Given this list of marker genes PDX1, COPA, STAT2, NF2, TET2, CHEK2, KCNJ5, BMPR1A, MYD88, VHL, BICD2, GP1BA, F11, XYLT2, LRP5, ERAP1, LBR, CST3, NF1, MDH2, ARPC1B, SLC7A7, CFHR1, MEN1, COMT, APC (APC regulator of WNT signaling pathway), JAK2, INS, PDCD1, CBL, TAOK1, CALR, CLCN2, PKHD1, GALE, PCCB, PROC, KIF1B, CNTNAP2, WIPF1, VWF, LAMB2, SMAD4, NLRC4, TBX20, ATM, DLST, PMS2, DOCK6, STK11, MUTYH, PET100, TERT (telomerase reverse transcriptase), GATA6, IL12A, WAS, SF3B1, SEMA4A, CAPN5, SBDS, MSH6, TERC, IFIH1, RPS20, DBR1, TTC7A, CD46, FIP1L1, GCDH (glutaryl-CoA dehydrogenase), SDHAF2, FBN1, CYP11B2, GATA4, SPARC (secreted protein acidic and cysteine rich), HLA-DPB1, MVK, FCGR2C, TLL1, CCM2, COL3A1, DZIP1L, CDKN1B, MARS2, SP110, ITGA2, CITED2, SDHB, FOXE3, ZNF408, F8, AKT1, STAT5B, RASA1, PLVAP, ZNFX1, IFNG, KCNJ11 (NCBI Gene Id 3767), AGGF1, RUNX1, FN1, ALPL, F9, MPI, ACAD9, ATRX, TRAF7, CYP7B1, HPS1 (HPS1 biogenesis of lysosomal organelles complex 3 subunit 1), F7, F13B, NKX2-5, KIT, MYH6, ATP6V1A, BEST1, BAP1, HPGD, NFIA, ACTA1, CACNA1D, SMAD2, GDF2, FLNA, STT3A, SDHC, HEY2, COL4A1, PDGFRA, COL4A2, UFD1, POT1, FOXF1, NPM1, CYP11B1, DNMT3A, NABP1, UBAC2, GP1BB, MYH11, GFI1B, POLD1, MMUT, SLC25A13 (NCBI Gene Id 10165), SEC63, MAX, SLCO2A1, MCFD2 (multiple coagulation factor deficiency 2, ER cargo receptor complex subunit), ATP6V1E1, SH2B3, CTCF, MFAP5, SMARCE1, CFHR3, DHPS, ACTA2, PLAU, NUMA1, MED12, F13A1, GP9, PRKAR1A, TGFB2 (transforming growth factor beta 2), CTNNB1, FSHR, ARPC5, KLRC4, F2, FZD4, ASXL1 (NCBI Gene Id 23393), RET, EPCAM, CTC1 (NCBI Gene Id 80169), CISD2, SLC35A1, STN1, CBS, DST, THOC6, IFT56, RARA, STAT3, MYC, ENPP1, GCK, RS1, FH, SERPINE1, KRIT1, SNORD118, RNF168, CDKN2C, ARHGAP31, TGFBR1 (NCBI Gene Id 7046), KRAS (KRAS proto-oncogene, GTPase), ANGPTL6, EPOR, IKBKG, STAT4, ATP7A, DLL4, GNA11, LMOD2, TMEM127, RACGAP1, HADHB (hydroxyacyl-CoA dehydrogenase trifunctional multienzyme complex subunit beta), JMJD1C, TBL1XR1, HBB, TSPAN12, ESAM, ABCC8, DPAGT1 (NCBI Gene Id 1799), DOCK8, IL12A-AS1, TINF2, HSD3B7, MMACHC, HMCN1, SDHD (succinate dehydrogenase complex subunit D), CTNS, PDCD10, RBPJ, MLH1, PUF60, RB1, CDKN2B, CDKN1A, SMARCB1, GATA2, POLE, GAA, PMM2, ABCC6, IL23R, ITGA2B, ZEB2, FGB, GBA1, IVD, TEK, SDHA, EOGT, PTPN22, ELN, FAH, HELLPAR, SMAD3, IL10, IRF4, EXT2, TGFB3, TSC1, SHARPIN, ADA2, IKZF1, PRKCSH (NCBI Gene Id 5589), F10, TBX1, IFNGR1, IRF2BP2, RANBP2, SIN3A, FGA, MSH2, RHBDF2, EFEMP1, NOTCH3 (NCBI Gene Id 791), CASP10, AVPR2, C4A, PTEN, DNM2, PRKG1, ERCC8, PDGFB, APOLD1, HLA-DPA1, TNXB, THSD1, SRSF2, WFS1, HLA-B, ACTC1, PIK3CA, KANSL1, ITGB3, PMS1, CFH, IPO8, AQP2, NDP, SREBF1, STX3, PRTN3, CTLA4, SMO, BRCA2, RBCK1, CCR1, PLOD1, THSD4, APOE, TGFBR3, MYO5B, ZFX, BCOR, F5, EIF2AK4, SUFU (SUFU negative regulator of hedgehog signaling), TSC2, GREM1, STIM1, FGG, RREB1, SLC25A11, LOX, LMAN1, SEC24C, GGCX, ACVRL1, CYP11A1, GNAQ, HIRA, NOTCH1, XYLT1, KIF23, CPT2, ATOH7, EPHB2, RBM10, MEFV, SMC5, CFI, EPAS1, PML, ENG, SAMD9, LMBRD1, NDE1, APP, FAS, HMOX1, CYP26C1, ATP6V0A2, PCCA, ZBTB16, CD109, BRCC3, AMACR, CYSLTR2, ZMPSTE24, IL10RA, ERCC6, TREX1, MAT2A, MYLK (NCBI Gene Id 50483), SERPINF2, TNFRSF1A, ARVCF, ALDOB, TMEM237, TGFBR2, PROS1, USP18, PRF1, LMNA, TLR4, here is a description of the gene set: Human Gene Set: HP_ABNORMALITY_OF_BLOOD_CIRCULATION studied in species Homo sapiens An abnormality of blood circulation. Abnormality of blood circulation